Given this list of marker genes RAC1, RRAGA, KCNB1, BSG, MADCAM1, RAB6C, PDZK1, GJD2-DT, SNAP25-AS1, BAG6, MTMR4, PPFIA1, RTP3, VPS52, BBIP1, SLC12A5, FLOT2, TIMM10, F11R, ADAM10, LLGL2 (NCBI Gene Id 3993), SPTBN4, HGS, NPTX1 (NCBI Gene Id 4884), CPLX1, MESD, TM9SF3, CMTM6, PPIL2, ATP6AP1, WDR83OS, AFDN, FLNA, SRPRB, WNT3A, SYNGAP1, EIPR1, NMT2, SRP54, DSG3, PTN (NCBI Gene Id 5764), SIL1, AP3B1, EMC10, TOMM40, RABGEF1, RAB14, NECAB2, THY1, FXR1, C2CD5, MIEF2, AGRN, PEX26, PREPL, LRRC7, LAMTOR1, PTPN23, CLTC, SCN3B, ICMT (isoprenylcysteine carboxyl methyltransferase), EXOC1, PHAF1, STOM, BBS1, ZDHHC12, CCDC93, SSH1, ZFYVE27, STX7, HPCA, SEC61A1, KIF13A, CD2, RSC1A1, IFT20, SNF8, ADIPOQ, ZFAND2B, PLS1, SLC4A1, DLG3 (NCBI Gene Id 89363), SCARB2 (NCBI Gene Id 950), REEP2, PPP2R5A, GHSR, VAMP3, TIMM10B, TIMM8B, CDH2, NHERF2, EMC1, DOCK2, CAV3, SRP9, JUP, PRKN, NOMO1, NETO2, CRIPT, VPS51, TSPAN33, CSK (C-terminal Src kinase), TREM2, GABARAP, IFNG, DAG1, NDRG4, ZDHHC23, YJEFN3, SNX7, TM9SF4, ITGB1, GOLPH3L, TIMM22, GPC1, EFR3A, ZDHHC20, NRXN1, RAPGEF6, ZDHHC11B, CD81, EHD4, TTC7A, VIL1, RAP2A, HPS6, ARHGAP44, PTPRC, GOLGA7B, CDK5R1, GPC3, STX8, SRPRA, SNX3, OXA1L, EHD3, TRAM1, NUMB, TOMM5 (NCBI Gene Id 644560), TGFB1, STXBP5L, NDUFA13, STAC2, ITGB1BP1, ZDHHC8, PID1, LMNB2, AP3D1, ZDHHC24, DENND4C, ATG3 (NCBI Gene Id 64422), WNK4, BAX, KCNE1, PEX3, IKBKB, FZD9, PRKCZ, SACM1L, NLGN2, ATP2B4, EPHA2, CACNA2D2, DMTN, GIT1, ZDHHC5, CCDC22, AP4M1, VPS37A, UMOD, SNX12, RAB35, PACSIN1, EPHA3, FLOT1, GSN, VPS50, SSR2, PACS2, RAMP1, SEC61G, EPB41L3, SEC62 (NCBI Gene Id 7095), ITGAM, GLP1R, DLG1, EGFR, GPER1, LAT, ITGAL, EMC7, STX12, EHD2, BAG4, ENTR1, MAP7, ZDHHC6, NOMO2, VPS53, NKD2, PEX19, RAB11FIP2, RAB3IP, RER1, SEC61B, RAB32, VPS26C, C1QL3, ARL5A, VPS35, RHOQ (ras homolog family member Q), PRKCI, CAMLG, RAB6D, TRAF6, GRIN2A, CAPN3, TSPAN15, ZDHHC21, ITGB3, HSP90B1, SPTBN1, GOLGA7, DENND1C, CHMP4B, ARFGEF2, MACF1, EPM2A, KIF5B, GOLPH3, RAB31, SLITRK3, STAC, CACNG5, TTC8, TTC7B, MYADM, RHBDF2, ATP2C2, LMTK2, GPHN, RTP4, RAB38, ZMYND8, MICALL1, NECTIN3, PSAP, LLGL1, TM9SF2, RAB8B, CACNG4, WDR19, TRAM2, MTX2, PGRMC1, FYB2, ARL4C, PRKG2, SGTB, CACNB3, ZDHHC18, SRP72, TMEM108, NAXE, USP17L2, CACNG7, BLTP1, BID, NACA2, SCP2, EXOC8, PLA2G4E, AP2M1, EMC9, ZDHHC3, AR, ATP13A1, VPS37D (VPS37D subunit of ESCRT-I), STAC3, SEC63, YPEL4, AKT1, DNAJA3, MTCL1, CNPY4, NMT1, GAK, ATP9A, CD53, PARD3, RAB5IF, EXOC6B, EMC3, PRKCE, S100A10, RAB17, VPS35L, LYPLAL1, TRARG1, ARHGEF16, VPS37B, RAB26 (NCBI Gene Id 25837), GRIPAP1, NHERF4, INS, GRIP1, SRP68, GRIN3B, GGA3, AGER (NCBI Gene Id 177), VPS39, MAP2K1, FNTA, RAB3GAP1, LHFPL4, CACNG8, RAB11FIP3, NLGN1, SLC30A1, ZDHHC7, ABI3, LDLRAP1, NSF, PEX5 (NCBI Gene Id 5830), VAMP4, NACA, TUB, MMP14, STX3, DENND1B, SNX31, SLC1A1, ARL3, RELN, LAMA5, STX4, KCNIP3, UBL4A, EPG5, BVES, ARL6IP1, PIK3R2, NOMO3, TOMM22, TNFAIP6, ACTN2, TIMM9, RILPL2, SNX17, ANK1, RN7SL2, RN7SL1, NUP54, GGA2, RAMP3, OLFM1, TRAM1L1, VAMP5, CACNG2, ABHD17A, COMMD1, MRAP, ARL6IP5, EPS15, GLRB, EMC2, COLQ, GPC2, CD24, CACNG3, TOMM6, EXOC5, CAMK2B, SORBS1, SLC7A11, RAPSN, NACAD, YIF1B, ARL5B, WASHC2C, ITGB2, EFR3B, STX6, ZDHHC14, VWC2, SNX27, WASH6P, IQSEC2, WIPF3 (NCBI Gene Id 648464), PTCH1, ANK2, TRMT10B, ERBB4, RAB11A, EZR, GOPC, WDR72, TSPAN14, WASHC1, ETV5, INPP5K, ABCA12, PKP3, RAB6A, RAB11FIP4, SLC5A3, CNST, RAB6B, NHLRC1, PIKFYVE (NCBI Gene Id 387568), RAB3GAP2, SMURF1 (SMAD specific E3 ubiquitin protein ligase 1), ERRFI1, TCAF2, TMEM59, TESC, TSPAN9, PALM, ZDHHC9, RFTN1, CAMK2D, AQP11, ARHGAP8, VPS13B (vacuolar protein sorting 13 homolog B), DAB2, VPS37C, STEAP2, PRAM1, NRXN2, EMC6, MYO5A, ARL13B, ATP1B1, WASH3P, ROMO1 (reactive oxygen species modulator 1), AGK, TIMM8A, APOE, MYO1C, ACAP2, RAB11B, SSR1, FGF13 (fibroblast growth factor 13), PKDCC, NME7, BHLHE40-AS1, RAP1A, AP2B1, NDC1, RAB13, C1QL2, RILPL1, NUP155, SRP19, ZDHHC22, PIK3R1, SLC51B, CCDC47, RDX, ANXA13, FRMD8, DENND1A, ANKRD13C, RAB34, GPC4, RAMP2, SDCBP, PIP5K1A, RRAGC, LGI1, ERBB2, GOLGA4, TPBG, SEC61A2, HYCC2, STXBP1, ARF6, CYP46A1, KCNIP4, GPSM2, EMC4, CDH1, NETO1, PIGR (polymeric immunoglobulin receptor), ZDHHC11, TOMM7, PRKCH, GGA1, NHERF1, SSR3, ARFRP1, NCLN, SYNE3, PICK1, CRKL, LRRC4, SFN, TIMM29, SQSTM1, LZTFL1, MAGI2, TMBIM1, FERMT2, CNIH3, WNK1, ATP2C1, SEC16A, MIEF1, KRT18, CALM3, MRAP2, ARHGAP1, MTCH2, KCNB2 (NCBI Gene Id 9312), TCAF1, TOMM70, NCF1, SORL1, REEP1, VAMP8, PALS1, GBP1, CIB1, PRNP, SRP14, COX18, GAS6, PICALM, TNFRSF1A, PKP1, SAMM50, SLMAP, LRP4, PTPN9, VPS4A, RTP2, STX1A, CHMP4A, OGT, RTP5, HSPA5, DOK7, MAL, TOMM20, PIGW, FYN, CDK5, HRAS, RAB29, NACA4P, VTI1A, KIF2C, BRAF, ANO1, P2RY1, BCL2L1, STXBP5, LYPLA1, SHISA6, CPE, RAB8A, HYCC1, AGR2, MUSK, OSBPL5, SPG11, C2CD6, DPP10, RAB7A, SYS1, BCS1L, PDZK1P1, TMEM126A, VPS26B (NCBI Gene Id 112936), ITGB7 (integrin subunit beta 7), GORASP2, FCHO2, ANK3, ADORA1, WNK3, FCER1G, APPL1, RABEP1, EPHB2, MAIP1, TTC9-DT, GDI1, GORASP1, OPTN, VAMP2, EXOC4, SHISA7, ZDHHC19 (zinc finger DHHC-type palmitoyltransferase 19), DLG2, TMEM88, INPP5F (NCBI Gene Id 22876), PEX16, PLA2G3, EHD1, TMEM147, TSPAN5, MTX1, SH3GLB1, MICALL2 (NCBI Gene Id 79778), TMED2, VPS29, PRPH2, CHRDL1, DCHS1 (NCBI Gene Id 8642), ZDHHC1, BBS2, RANGRF, CEMIP, EFCAB7, SNX4, CDH13, GPC5, TMCO1, PLEKHF1, ACSL3, LGALS3, CWH43, SKAP1 (NCBI Gene Id 8631), CLIP3, ITGA3, PKP2, ARL5C, RN7SL3, PAK1, CRB3, VPS26A, ZDHHC2, GPC6, RTP1, RHOG, RALA, AKT2, MTCH1, AMN, TM9SF1, GRIP2, STX16, FYB1, ROCK2, LARGE1, ZDHHC15 (NCBI Gene Id 158866, zinc finger DHHC-type palmitoyltransferase 15), EXOC6, GET4, ARL6, ROCK1, CSRP3, DVL1, CLN3, CCDC88A, LYPD1, ANKRD27, RAB10, SH3PXD2B, CAMK2A, SCRIB, ATAD1, ENSG00000283175, CHP1, TIMM13, NSG1, SEC23A (SEC23 homolog A, COPII coat complex component), ATP1B3, CLSTN1, RAB41, EMC8, IFT80, ANKRD50, GET1, RAPGEF2, GRIN2C, SGTA, ACTB, TNF, EXOC2, MMGT1, SHANK3, PACS1, DEF6, DLG4, SIRT6, SSNA1, GET3, MOAP1, DPP6, LRP6, LMNB1, ZDHHC4, CAV1, NPC1, PIK3CA, FARP1, TNIK, GRIK2, GCC2, LRP1, CHM, SNX30, CAMK2G, RACK1, BLZF1, CACNB2, ARL13A, PDPK1, LRRC15, TAOK2, ITGA4, PPP1R9B, AKAP5, LMNA, VTI1B, RAB12, CRK, GPR158, FRMPD1, TMEM150A, EMP2, FRRS1L, MIR223, here is a description of the gene set: Human Gene Set: GOBP_LOCALIZATION_WITHIN_MEMBRANE Any process in which a substance or cellular entity, such as a protein complex or organelle, is transported to, and/or maintained in, a specific location within a membrane. species: Homo sapiens